Given this list of marker genes Akr1c14, Akr1c6, Akr1c18, Akr1d1, Akr1c20, Akr1cl, Akr1c12 (aldo-keto reductase family 1, member C12), Akr1c19, Akr1c13, Akr1c21, here is a description of the gene set: Catalysis of the reaction: O2 + NADPH + progesterone = H2O + NADP+ + testosterone acetate. species: Mus musculus Mouse Gene Set: GOMF_KETOSTEROID_MONOOXYGENASE_ACTIVITY